Given this list of marker genes Nanog, Nodal, Lefty1, Lefty2, Cripto, Pou5f1, here is a description of the gene set: Mouse Gene Set: TESAR_ALK_AND_JAK_TARGETS_MOUSE_ES_D4_DN from publication Tesar PJ, Chenoweth JG, Brook FA, Davies TJ, Evans EP, Mack DL, Gardner RL, McKay RD (PMID 17597760) Genes down-regulated in mES cells (mouse embryonic stem cells) after tratment with the ALK inhibitor SB-431542 and JAK inhibitor I. species: Mus musculus The application of human embryonic stem (ES) cells in medicine and biology has an inherent reliance on understanding the starting cell population. Human ES cells differ from mouse ES cells and the specific embryonic origin of both cell types is unclear. Previous work suggested that mouse ES cells could only be obtained from the embryo before implantation in the uterus. Here we show that cell lines can be derived from the epiblast, a tissue of the post-implantation embryo that generates the embryo proper. These cells, which we refer to as EpiSCs (post-implantation epiblast-derived stem cells), express transcription factors known to regulate pluripotency, maintain their genomic integrity, and robustly differentiate into the major somatic cell types as well as primordial germ cells. The EpiSC lines are distinct from mouse ES cells in their epigenetic state and the signals controlling their differentiation. Furthermore, EpiSC and human ES cells share patterns of gene expression and signalling responses that normally function in the epiblast. These results show that epiblast cells can be maintained as stable cell lines and interrogated to understand how pluripotent cells generate distinct fates during early development.